The following is a description of a gene set: COMMD1 (previously known as MURR1) belongs to a novel family of proteins termed the copper metabolism gene MURR1 domain (COMMD) family. The 10 COMMD family members are well conserved between vertebrates, but the functions of most of the COMMD proteins are unknown. We recently established that COMMD1 is associated with the hepatic copper overload disorder copper toxicosis in Bedlington terriers. Recent in vitro studies indicate that COMMD1 has multiple functions, including sodium transport and NF-kappaB signaling. To elucidate the function of Commd1 in vivo, we generated homozygous Commd1 null (Commd1(-/-)) mice. Commd1(-/-) embryos died in utero between 9.5 and 10.5 days postcoitum (dpc), their development was generally retarded, and placenta vascularization was absent. Microarray analysis identified transcriptional upregulation of hypoxia-inducible factor 1 (HIF-1) target genes in 9.5-dpc Commd1(-/-) embryos compared to normal embryos, a feature that was associated with increased Hif-1alpha stability. Consistent with these observations, COMMD1 physically associates with HIF-1alpha and inhibits HIF-1alpha stability and HIF-1 transactivation in vitro. Thus, this study identifies COMMD1 as a novel regulator of HIF-1 activity and shows that Commd1 deficiency in mice leads to embryonic lethality associated with dysregulated placenta vascularization. Genes down-regulated in normal 9.5 days post coitus (dpc) embryos compared to normal 8.5 dpc and 9.5 dpc embryos. from publication van de Sluis B, Muller P, Duran K, Chen A, Groot AJ, Klomp LW, Liu PP, Wijmenga C (PMID 17371845) Mouse Gene Set: VANDESLUIS_NORMAL_EMBRYOS_DN studied in species Mus musculus, and this is the list of marker genes: Basp1, Pf4, Slc39a6, Or1e1c, Pcolce, Vim, Alas2, Hbb-bh1, Crtc1, Hbb-y, Hp1bp3 (NCBI Gene Id 15441), Cabp1, Hs3st1, Hoxc10, Pop4, Hba-a1, Iapp, Tesk1 (testis specific protein kinase 1), Nudt4, Hba-x (hemoglobin X, alpha-like embryonic chain in Hba complex), Kcnh2